The following is a description of a gene set: species: Homo sapiens Human Gene Set: GOBP_ADENYLATE_CYCLASE_ACTIVATING_SEROTONIN_RECEPTOR_SIGNALING_PATHWAY An adenylate cyclase-activating G protein-coupled receptor signaling pathway initiated by serotonin binding to its receptor, and ending with the regulation of a downstream cellular process., and this is the list of marker genes: ADCY6, HTR7, HTR4, GNAS, HTR6